Given this list of marker genes TBX5, VAC14, BMPR1B, FANCD2, FIG4, TRIO, SHH, LMBR1, XRCC2, here is a description of the gene set: species: Homo sapiens Human Gene Set: HP_APLASIA_OF_THE_PROXIMAL_PHALANGES_OF_THE_HAND Aplasia of the proximal phalanges of the hand